The following is a description of a gene set: Excessive, increased hair growth located in the facial region. species: Homo sapiens Facial hypertrichosis Human Gene Set: HP_FACIAL_HYPERTRICHOSIS, and this is the list of marker genes: UBE2A, CLCN3, OGT, TMCO1, KCNK4, GABRA3 (gamma-aminobutyric acid type A receptor subunit alpha3), BRD4, UGP2, NUDT2, KDM4B, SPEN, MAP1B, DDB1, VPS33A, NMNAT1, UBAP2L, CDC42, CNTNAP2, PPP1R15B, SLC25A24, RAB34, AFF3, RAC1, PAX3, GJA8 (NCBI Gene Id 2703), ZNF711, TRAPPC10, ANKRD11, FRA10AC1, ASXL1, SMC3, SGSH, IL1RAPL1, GATA1, HEATR3, HGSNAT, HNRNPU, GNS, SCN4A, GNE, SETBP1, SPOP, DEAF1, XYLT1, ZNF292, MAB21L1, TRAPPC9, MITF, AFF4, CLP1, CTCF, BICRA, EP300, PACS1, CASP2, FHL1, SLC4A10, TBCD, IGF1R, UQCC2, CSNK2A1 (casein kinase 2 alpha 1), MASP1, SOX10, TUBGCP2, TMEM147, NECTIN1, SLC32A1, RUSC2, TRIM8, MED27, TRMT10A, FBXO28, CWF19L1, STAG1, POLR3A, UFC1, CHSY1, FBXO31, ARX, SNAI2, EBF3, UROD, CCDC47, CDH11 (cadherin 11), SMS, FGF3, NSUN2, TASP1, ARID1B, EDN3, FLII, ASXL3, NFIX, SMARCA2, PSMC3, MAPK8IP3, PCDHGC4, TRMT1 (tRNA methyltransferase 1), RAD21, IQSEC2, ZNF699, AMMECR1, PRKG2 (NCBI Gene Id 5593), NOTCH2, DYM, FREM1 (FRAS1 related extracellular matrix 1), NANS, HECTD4, CHD5, CUL4B, B3GLCT, AIP, ATP6V1B2, PHF8, ASH1L, UROS, RAB3GAP1, ACTB, TAF6, TMEM94, SNX14, ESAM, FGFR1, MED13, KNL1, FBXL4 (NCBI Gene Id 26235), AHDC1, EMC10, PHIP (pleckstrin homology domain interacting protein), CDON, COX5A, ASXL2, BPTF, PTCH1, RPS23, CDK10, KLF13, TTI2, TOE1, ARL3, KDM1A, CDH2, PIGN, RAI1, CDKL5 (NCBI Gene Id 6792), HMGA2, TFE3, HDAC8, ZFX, CHMP1A, SMC1A, ADAT3, NAGLU, ALG9, BMP2, NKX6-2, PSMD12, ZMYND11, SETD5, SLC1A4, ERLIN2, PACS2, KCNMA1, GNB2, ADAMTS3, ZNF407, KCNN3, KIFBP, MAPRE2, TAF4, DHX30, EHMT1, KATNB1, UGDH, HID1, MBD5, TBCK, EDNRB, WAC, INSR, EIF4A2, ABCA5, WNT4, ZBTB20, DOCK7, CERT1, ZIC2, KIF26A, TRIO, TALDO1, TAF1, SMCHD1 (NCBI Gene Id 2490), HSPA9, NDST1, GJA5, PLCB4, BCAS3, PRR12, CREBBP, HIVEP2, SPTBN1, CHRNA7, KIT, JARID2, KCNH1, WARS1, CDC42BPB, GPR101, KMT2A, NIPBL, LEMD3